Given this list of marker genes SLC25A6, SLC25A33, SLC35D3, SLC35B4, SLC17A9, SLC25A53, SLC35A3, SLC35D1, ABCC4, ABCD2, SLC25A5, SLC44A4, SLC35A5, PANX1, SLC35B1, SLC25A17, SLC37A3, SLC35B3, SLC37A1, SLC25A16, SLC25A19, SLC35A4, SLC25A4, SLC35A1, SLC25A24, SLC35E3 (NCBI Gene Id 55508), SLC33A1, SLC25A52, SLC25A32, SLC35D2, SLC35A2, ABCD1, SLC35B2, SLC46A2, SLC37A4, LRRC8A, SLC25A25, ANKH, ABCC11, TMEM241 (NCBI Gene Id 85019), ABCC5, SLC25A36, SLC19A1, SLC25A41, SLC35C1, SLC25A31, SLC37A2, MFSD2A, SLC25A51, SLC25A42, SLC25A23, SLC25A47, here is a description of the gene set: Enables the transfer of organophosphate esters from one side of a membrane to the other. Organophosphate esters are small organic molecules containing phosphate ester bonds. Human Gene Set: GOMF_ORGANOPHOSPHATE_ESTER_TRANSMEMBRANE_TRANSPORTER_ACTIVITY species: Homo sapiens